The following is a description of a gene set: part of: FGFR2 ligand binding and activation Reactome Pathway: FGFR2c ligand binding and activation studied in species Homo sapiens This pathway depicts the binding of an experimentally-verified range of ligands to FGFR2c. While binding affinities may vary considerably within this set, the ligands listed have been established to bring about receptor activation at their reported physiological concentrations., and this is the list of marker genes: FGF20, FGF16, FGF23, FGF5, FGF4, FGF1, FGF18, FGFR2, FGF17, FGF6, FGF8, FGF2, FGF9